The following is a description of a gene set: Mouse Gene Set: GOMF_INTRAMOLECULAR_TRANSFERASE_ACTIVITY Catalysis of the transfer of a functional group from one position to another within a single molecule. studied in species Mus musculus, and this is the list of marker genes: Pus1, Pus10, Pgm5, Rpusd4, Rpusd1, Aloxe3, Pgm2, Pgm3, Bpgm, Dkc1, Pus7l, Tmem86b, Rpusd2, Trub2, Pmm1, Pgam1, Pmm2, Rpusd3, Pus7 (pseudouridylate synthase 7), Pus3, Pgm1, Lss, Pusl1, Pgam2, Mmut, Trub1, Alox15, Pgm2l1